The following is a description of a gene set: Human Gene Set: GOBP_GLUTAMINE_TRANSPORT species: Homo sapiens The directed movement of glutamine, 2-amino-4-carbamoylbutanoic acid, into, out of or within a cell, or between cells, by means of some agent such as a transporter or pore., and this is the list of marker genes: SLC1A4, SLC38A3, SLC38A1, SLC1A5, SLC38A5, SLC38A6, SLC38A2, LEP, SLC38A9, SLC38A7